The following is a description of a gene set: species: Homo sapiens The presence of multiple xanthomas (xanthomata) in the skin. Xanthomas are yellowish, firm, lipid-laden nodules in the skin. Xanthomatosis Human Gene Set: HP_XANTHOMATOSIS, and this is the list of marker genes: PCSK9, SPIB, LMNA, GHR, EPHX2, LPL, IL12RB1, LDLRAP1, LDLR, ABCG5, ABCG8, GPIHBP1, LIPC, MMEL1, APOA2, APOA1, SPRED1, POU2AF1, PPP1R17, APOE, PPARG, STAT3, PDGFRB, SLC37A4, APOB, APOC2, IRF5, TNPO3, KRAS, APOA5, ABCA1, LMF1, SMPD1, IL12A, FGFR1, TNFSF15, TTPA, CYP27A1, G6PC1 (NCBI Gene Id 2538)